The following is a description of a gene set: Neighborhood of SMC4L1 Human Gene Set: GNF2_SMC4L1 species: Homo sapiens Neighborhood of SMC4L1 NULL in the GNF2 expression compendium, and this is the list of marker genes: SMC4, SUPT16H, RAD51AP1, AURKA, KIF11, NASP, MCM3, DUT, PCLAF, GINS2, PCCB, CDC20, SSRP1, TYMS, FOXM1, CCNA2, EIF2S1, SNRPD1, BUB1B (BUB1 mitotic checkpoint serine/threonine kinase B), RRM1, MRPL35, HAT1, HNRNPAB, DEK (NCBI Gene Id 7913), DLGAP5, H2AX, DTYMK, SLBP, GAR1 (NCBI Gene Id 54433), PRIM1, ANP32B, SERBP1, E2F8, SNRPG, CKS2, MCM2, FBXO5, DHFR, FEN1, CKAP2, PLK4, METAP2, COPS3, RACGAP1, HNRNPA3P1, DKC1, PCNA, TOP2A, EXOSC8, DTL, TMPO, VRK1, POLE2, CDK1, MSH2, KIF18B, GINS1, SHCBP1 (NCBI Gene Id 79801), CDCA8, DNAJC9, RFC4, NUSAP1, MCM7, ANP32E, HMMR, ZWINT, MCM5, CCNB2, RFC3, SMC2, CBX3, NUP153, TTK, MCM4, ASPM, SRSF1 (NCBI Gene Id 650453), PRC1, NDC80, USP1, ZWILCH, FANCI, HMGB2, CENPF, GMNN